The following is a description of a gene set: Cytosolic hexokinase 1 (HK1), together with isoforms HK2 and 3 and glucokinase (GCK), catalyse the irreversible reaction of alpha-D-glucose (Glc) and ATP to form alpha-D-glucose-6-phosphate (G6P) and ADP, the first step in glycolysis. HK1 is the predominant isoform of the different HKs in tissues that utilise glucose for their physiological function such as brain, lymphocytes, erythrocytes, platelets and fibroblasts. Defects in HK1 can cause hexokinase deficiency (HK deficiency; MIM:235700), a rare, autosomal recessive disease with nonspherocytic hemolytic anemia as the predominant clinical feature. part of: SLC transporter disorders species: Homo sapiens Reactome Pathway: Defective HK1 causes hexokinase deficiency (HK deficiency), and this is the list of marker genes: HK1